Given this list of marker genes Enam, Cftr, Odaph, Amtn, Slc4a2, Dspp (dentin sialophosphoprotein), here is a description of the gene set: species: Mus musculus Mouse Gene Set: GOBP_POSITIVE_REGULATION_OF_ENAMEL_MINERALIZATION Any process that activates or increases the frequency, rate or extent of enamel mineralization, the deposition of calcium salts in tooth enamel.